The following is a description of a gene set: from publication Tabula Muris Consortium (PMID 32669714) Mouse Gene Set: TABULA_MURIS_SENIS_MARROW_HEMATOPOIETIC_PRECURSOR_CELL_AGEING studied in species Mus musculus, and this is the list of marker genes: Slfn2, Itm2b, Id2, Rnasek, Cd74, Wfdc21 (NCBI Gene Id 66107), Rabac1, Cdk2ap2, Cd9, Tmsb4x, Serpina3g, Cd3e, AW112010, Ly6a, Chil3, Ctsb, Pglyrp1, Cd24a, H2-D1, Itm2c, Malat1, Anxa2, Ms4a6b, Xcl1, Cd3g, Sat1, Fau, B2m, Gabarap, Itgb2, Ccl5, Lsp1, Tyrobp, Glrx, Gsr, Btg1, Lgals3, Ms4a4b, Prdx5, Lcn2 (NCBI Gene Id 99344), S100a6, H2-Eb1, S100a8, Tspo, Gimap3, Slpi, Thy1, Camp, Cd8b1, Shisa5, Lyz1, Tmbim6, Hp, Hcst, Capns1 (calpain, small subunit 1), Lime1, Bcl2a1b, Tnfrsf18, Gpsm3, Rsrp1, Cd2, Aldoa, Sh2d1a, Ngp, Cnn2, Lat, Nkg7, Map1lc3b, Saraf, Vsir, Anxa1, Rac2, Cd3d, S100a4, Cd52, Cyba, Grina, S100a11, Retnlg, H2-Ab1, Ltb, Dstn, Vasp, 4930523C07Rik, Ccl6, Msrb1, H2-K1, Prr13 (proline rich 13), H2-Aa, Ifitm6, Cd82, S100a9, Ostf1, H2-Q4, Ltf (lactotransferrin), Lyz2, Tmem254, Alox5ap, Pfdn5, Gimap7, Gimap4, Lck, Ptpn18